Given this list of marker genes Grip1, Phactr3, Nfat5, Usp25 (ubiquitin specific peptidase 25), Ugdh, Fyn (NCBI Gene Id 14360), Cth, Olr1, Cd247, Tnrc6b (trinucleotide repeat containing 6b), Zc3h6, Pcdhb11, Tnrc6a, Yme1l1, Nhs, Cep57, Elavl4, Klhl2, Itfg1, Dmrtb1, Arap2 (ArfGAP with RhoGAP domain, ankyrin repeat and PH domain 2), Thrap3, Scn9a, Dtx3l, Dnmt3b, Antxr2, Slit2, Fkbp14 (FK506 binding protein 14), Ppm1l, Cyrib, Pter, Btbd3, Ankrd12, Arhgap42, Ipcef1, Zbtb41, Tank, Pdpk1, Psma2, Zic1, Zdhhc2, Gpc4, Hif1a, Cep95, Neurod6, Stk17b, Ppp1r12a, Galnt7, Arhgap6, Pfdn4, Zfp638, Sobp, Tent2, Jarid2, Phf14, Nfkbiz, Ankrd34b, Gse1, Meis2, Kif1b, Togaram1, Ptpre, Acsl4, Fosl1, Tet1, Zfp518a, Iqub, Pitx2, Mettl9, Plek, Ubn2, Arpp21, Myof, Bckdhb, Lpar4, Cpeb2, Erc1, Purg, Wdr82, Nucks1, Rimklb, Mbnl1, Cdc25a, Smap1, Rad23a, Zfp383, Tcf4 (NCBI Gene Id 67762), Golph3, Trappc2b, Ank, Trps1, Gpm6b, Kif3c, Ywhag, Mindy2, Tmtc3, Clasp1, Agtr2, Prdm2, Nfyb, Cdk19, Vcf2, Slc9a6, Pigz (phosphatidylinositol glycan anchor biosynthesis, class Z), Wdr36, Etnk1, Ino80d, Mre11a, Dnal1, Apbb1ip, Ift88, Osbpl8, Cd48 (NCBI Gene Id 98728), Lum, Zfp207, Sypl1, Grk3, Cttnbp2nl, Map2k4, Garem1, Ndufs1, Jrkl, Zfp781b, Hecw2, Scaf8, Tfap2b, Dipk2a, Tph1, Mycn, Kmt2e (NCBI Gene Id 78559), Dip2a, Zfp141, Slc8a1, Pik3ca (phosphatidylinositol-4,5-bisphosphate 3-kinase catalytic subunit alpha), Sp4, Rimoc1, Kcnj12, Rmdn2, Kctd8, Tmem64, Braf, Klf11, Cul4b, Spata31, Man1a, Vbp1, Phf20l1, 2210408I21Rik, Ube2v2, Zfand4, Vmp1, Fam76b, here is a description of the gene set: species: Mus musculus from publication Chen Y, Wang X (PMID 31504780) Mouse Gene Set: MIR_322_3P Genes predicted to be targets of miRBase v22 microRNA mmu_miR_322_3p in miRDB v6.0 with MirTarget v4 prediction scores > 80 (high confidence targets).